The following is a description of a gene set: studied in species Mus musculus Mouse Gene Set: GOCC_CLATHRIN_SCULPTED_GLUTAMATE_TRANSPORT_VESICLE A clathrin-sculpted lipid bilayer membrane-enclosed vesicle after clathrin release and containing glutamate., and this is the list of marker genes: Syn1, Otof, Vamp2, Syp, Dnajc5, Rab3a, Slc17a8